Given this list of marker genes Crb2, T2, Efna1, Epha2, T, here is a description of the gene set: studied in species Mus musculus The formation of the notochord from the chordamesoderm. The notochord is composed of large cells packed within a firm connective tissue sheath and is found in all chordates at the ventral surface of the neural tube. In vertebrates, the notochord contributes to the vertebral column. Mouse Gene Set: GOBP_NOTOCHORD_FORMATION